The following is a description of a gene set: Mouse Gene Set: REACTOME_TIGHT_JUNCTION_INTERACTIONS Tight junction interactions species: Mus musculus, and this is the list of marker genes: Prkci, Pard3, F11r (NCBI Gene Id 226655), Pard6g, Pard6b, Pard6a